Given this list of marker genes PIK3CD, AKT2, EGFR, BAD, AKT1, EGF, AKT3, PIK3CB, PIK3CA, here is a description of the gene set: studied in species Homo sapiens Pathway Definition from KEGG: EGF -> EGFR -> PI3K -> PIP3 -> AKT -| BAD EGF-EGFR-PI3K signaling pathway. Pathway ID: N00033. Pathway type: Reference. Pathway class: nt06260 Colorectal cancer. Human Gene Set: KEGG_MEDICUS_REFERENCE_EGF_EGFR_PI3K_SIGNALING_PATHWAY